Given this list of marker genes D1Pas1, Ddx4, Piwil4, Helz, Tdrd9, Mael, Tdrd1, Ddx3x, Tdrd7, Tdrd5, Ago2, Carhsp1, Mov10l1, Tdrkh, Tdrd6, Mov10, Asz1, Piwil1, Snrpg, Piwil2, Gtsf1, Henmt1, Ankrd34c, Helz2, Ddx3y, Exd1 (exonuclease 3'-5' domain containing 1), here is a description of the gene set: Mouse Gene Set: GOCC_POLE_PLASM species: Mus musculus Differentiated cytoplasm associated with a pole (animal, vegetal, anterior, or posterior) of an oocyte, egg or early embryo.